The following is a description of a gene set: Human Gene Set: HERNANDEZ_ABERRANT_MITOSIS_BY_DOCETACEL_2NM_UP Among microtubule-targeting agents, docetaxel has received recent interest owing to its good therapeutic index. Clinical trials have underlined its potential for the treatment of advanced breast cancer, although little is known about its molecular mode of action in this context. We characterized the molecular changes induced by docetaxel in two well-known human breast carcinoma cell lines. Two mechanisms of action according to drug concentration were suggested by a biphasic sensitivity curve, and were further validated by cell morphology, cell cycle and cell death changes. Two to four nanomolar docetaxel induced aberrant mitosis followed by late necrosis, and 100 nM docetaxel induced mitotic arrest followed by apoptosis. Passing through mitosis phase was a requirement for hypodiploidy to occur, as shown by functional studies in synchronized cells and by combining docetaxel with the proteasome inhibitor MG132. Transcriptional profiling showed differences according to cell line and docetaxel concentration, with cell cycle, cell death and structural genes commonly regulated in both cell lines. Although p53 targets were mainly induced with low concentration of drug in MCF7 cells, its relevance in the dual mechanism of docetaxel cytotoxicity was ruled out by using an isogenic shp53 cell line. Many of the genes shown in this study may contribute to the dual mechanism by which docetaxel inhibits the growth of breast cancer cells at different concentrations. These findings provide a basis for rationally enhancing docetaxel therapy, considering lower concentrations, and better drug combinations. Genes up-regulated in MDA-MB-231 cells (breast cancer, mutated TP53) undergoing aberrant mitosis and necrosis after treatment with 2 nM docetaxel. from publication Hernández-Vargas H, Palacios J, Moreno-Bueno G (PMID 17099726) species: Homo sapiens, and this is the list of marker genes: CHST11, VHL, ZFP90, MST1L, RASGRF1, VLDLR, SLCO4C1, CRLF1, MLANA, CASP7, PIK3R1, KLRC3, MCAM, BTRC, MIF-AS1, HMOX1 (heme oxygenase 1), TYRP1, WRN, PLA2G15, NR1H2, PXK, MAF, H2BC21, BNC2, NTN4, SLC6A8, THBS2, PDZK1IP1, AGT, TYR, ARHGDIB, CD3D, N4BP2L1, PRSS23, SERPINF1, IFI44 (interferon induced protein 44), NR4A3, NIPAL3, NPAS2, CGA, IQGAP2, PLA2R1, EPAS1, PTPN3 (protein tyrosine phosphatase non-receptor type 3), ERBB3, HOXB2, TIMP2, MARCKS, PBDC1, TGFBR3, LPAR6, MYB, SGK1, IGF1R, USP4, FOLH1, FILIP1L, RAB31, ASNS (NCBI Gene Id 440), SLC35G2, SH2D1A, SSBP2, IFI16, DCT, GABBR2, PRKD3, LCP1, IL1RAP, THBD, PTPRM, PPP2R3A